Given this list of marker genes IFNB1, IRF7, TLR4 (NCBI Gene Id 7099), IRF3, IKBKE, TICAM1, TICAM2, TBK1, TRAF3, here is a description of the gene set: TLR4-IRF3/7 signaling pathway. Pathway ID: N00553. Pathway type: Reference. Pathway class: nt06517 TLR signaling. Pathway Definition from KEGG: TLR4 -> TICAM2 -> TICAM1 -> TRAF3 -> (IKBKE+TBK1) -> (IRF3,IRF7) => IFNB1 Human Gene Set: KEGG_MEDICUS_REFERENCE_TLR4_IRF3_7_SIGNALING_PATHWAY studied in species Homo sapiens